The following is a description of a gene set: studied in species Homo sapiens Obstruction of the flow of urine through the ureter. Ureteral obstruction Human Gene Set: HP_URETERAL_OBSTRUCTION, and this is the list of marker genes: APC2, CTLA4, MYOD1, NSD1, ATP7A, LAMB3, GNB1, HOXA13, ZMYM2, NODAL, TBX18, SLC35A2, HLA-DPA1, HLA-DPB1, YY1, PTPN22, MAP3K7, SIX1, DHCR7 (7-dehydrocholesterol reductase), EYA1, FLNA, PIGL, KDM6A, LAMA3 (laminin subunit alpha 3), DSTYK, BRF1, KMT2D, SF3B2 (splicing factor 3b subunit 2), PRTN3 (proteinase 3), HNF1B, LAMC2, GRHPR, PIGT, SIX5, SOX17, SLC26A1, CDH11, SETBP1, EHMT1